The following is a description of a gene set: Carboxyterminal post-translational modifications of tubulin species: Homo sapiens Human Gene Set: REACTOME_CARBOXYTERMINAL_POST_TRANSLATIONAL_MODIFICATIONS_OF_TUBULIN, and this is the list of marker genes: SVBP, TUBA8, AGBL1, TUBB8B (NCBI Gene Id 260334), TTLL7, TUBB8, TTLL8 (tubulin tyrosine ligase like 8), TTLL4 (NCBI Gene Id 9654), TUBB4A, TUBA1C, TUBA4A, TTLL3, TTLL12, AGTPBP1, TUBA4B, TUBB6, TUBA3E, TUBB4B, TUBA1B, TUBA3C, TTLL1, TTLL10, TUBB2A, NICN1, TUBAL3, AGBL3, TUBB1, TUBB3, TPGS1, AGBL2 (AGBL carboxypeptidase 2), TTLL6, TTLL5, TUBA3D, LRRC49, TTLL2, TTLL13, TTLL9, VASH1, TUBA1A, TUBB2B, AGBL4, TPGS2, AGBL5, VASH2, TTLL11, TTL